The following is a description of a gene set: Human Gene Set: chr15q12 species: Homo sapiens, and this is the list of marker genes: LINC02248, RNA5SP390, GABRB3 (NCBI Gene Id 2562), ATP10A, TVP23BP1, LINC02250, RNA5SP391, MIR4715, ENSG00000289522, GABRG3-AS1, LINC00929, GABRG3, SERPINE4P, ENSG00000212604, LINC02346, ATP10A-DT, GABRA5